The following is a description of a gene set: studied in species Mus musculus Binding to a CCR10 chemokine receptor. Mouse Gene Set: GOMF_CCR10_CHEMOKINE_RECEPTOR_BINDING, and this is the list of marker genes: Cxcl13, Ccl19-ps1, Ccl25, Ccl19-ps3, Ccl19-ps6, Ccl19-ps4, Ccl19, Ccl19-ps5